The following is a description of a gene set: Mouse Gene Set: GOBP_REGULATION_OF_GONADOTROPIN_SECRETION Any process that modulates the frequency, rate or extent of the regulated release of a gonadotropin. species: Mus musculus, and this is the list of marker genes: Crh, Inhba, Inhbb, Acvr2a, Npvf, Gja1, Tacr2, Ucn2 (NCBI Gene Id 171530), Kiss1, Oprk1, Oprm1, Crhr2, Inha, Smad4, Lep, Foxl2